Given this list of marker genes ATP2A2, GPR85, IL15, SFMBT1, CLRN3, MRPL50, RNF146, CDK5, CARS1, ATP6V1A (ATPase H+ transporting V1 subunit A), HPS3, TJP1, SRP54, NAPG, TRMT2A, FCGR3A, TMEM165, PTBP2, NDRG3, IFIH1, PTK2, HSP90AA1, LIPT2, SKP1, BBLN, FCHO1, GHITM, HECTD1, RNF135, TAF1B, RNF11, EOLA1, FNBP4, APAF1, ABR (NCBI Gene Id 82701), CFAP97 (NCBI Gene Id 57587), TM4SF5, FNDC3A, RAB24, TBC1D10B, KLHDC3, EHMT2, CDC73, DIPK2A, COG8, CIAO2B, CDC42SE2, YY1, ANXA6, ARIH1, ADCYAP1, DRG1, RAB8A, RASGRP1, FZD7, CMTR1, PSMB5, PCNX1, COX17, TMEM199, INSIG2, ARL14EP, TNKS2, LCP2, MORN4, ABCG2, GALNT6, DNAJC18, IL18BP, DUSP19, SPOP, CAPZA1, SMARCAD1, PGAM2, EED, CACYBP, PTGIR, LACTB2, POLA2, LTA (NCBI Gene Id 4049), LARS1, PSMB7, AGFG2, ATAD1, CWC27, DENR, NXT1, FKBPL, ARHGEF12, NOA1, BANP, PCGF6, SERF2, CMPK2, RGS1, SHPRH, HSBP1 (heat shock factor binding protein 1), TMEM263, TM9SF3, SYPL1, NAMPT, HNRNPH3, NT5C3A, ARHGAP21, MOB2, MSN, SLC6A8, LOXL3, AMFR, RBM7, MED14, SLC35A1, KDR, WDR48, CCNI, CAND1, PRICKLE1, UBE2O, IL36A, FBXW11, MEMO1, SEC23B (NCBI Gene Id 980), MGST1, SERPINB9, RABIF, FAM174A, KCTD14, RRS1, ABRACL, SNX18, CD47, EIF3E, SREK1IP1, HVCN1, GPCPD1, SLC22A4, TEFM, HMMR, TRIM27, SNHG8, LTN1, C3AR1, SLK, NRF1, COQ8A (NCBI Gene Id 56997), CASP8, SDF2, COPB1, GLMP, GNPTAB, SPIDR, UBR4, PXMP2, RNF10, TAX1BP1, CHD1, NGRN, ALKBH3, ETFRF1, CCNL2, SACM1L, SOCS3, LATS1, DEF8, PPP2CA, CREBZF, RUSC2, JAK1, MTURN, RAB18, HSD11B1, C16orf87 (NCBI Gene Id 388272), RIMOC1 (NCBI Gene Id 285636), HLA-C, TNF, ATP6V0B, IGSF9, CYRIB, DYNC1LI1, TMEM97, C8orf82, NFAT5, DALRD3, GADD45B, ZNF260, ZNF227, HSD3B7, PIAS2, IFITM3, TMCC3, ENPP2, CD274 (NCBI Gene Id 29126), SOCS4, COPS2, PAGR1, NUPR1, TMCO3, TMEM129, VAV1, ARFGEF1, here is a description of the gene set: Human Gene Set: GSE17721_0.5H_VS_24H_GARDIQUIMOD_BMDC_DN species: Homo sapiens from publication Amit I, Garber M, Chevrier N, Leite AP, Donner Y, Eisenhaure T, Guttman M, Grenier JK, Li W, Zuk O, Schubert LA, Birditt B, Shay T, Goren A, Zhang X, Smith Z, Deering R, McDonald RC, Cabili M, Bernstein BE, Rinn JL, Meissner A, Root DE, Hacohen N, Regev A (PMID 19729616) mouse primary BMDCs were stimulated with tlr ligands and gene expression changes were profiled on Affymetrix arrays Genes down-regulated in comparison of dendritic cells (DC) stimulated with Gardiquimod (TLR7 agonist) at 0.5 h versus those stimulated with Gardiquimod (TLR7 agonist) at 24 h.